The following is a description of a gene set: Human Gene Set: HP_PALMAR_TELANGIECTASIA Palmar telangiectasia The presence of telangiectases on the skin of palm of hand. studied in species Homo sapiens, and this is the list of marker genes: ACVRL1, GPR35, SOX18, TCF4, LBR (NCBI Gene Id 653311, lamin B receptor), MST1, SEMA4D